The following is a description of a gene set: studied in species Homo sapiens Human Gene Set: GOCC_EUKARYOTIC_TRANSLATION_INITIATION_FACTOR_2B_COMPLEX A multisubunit guanine nucleotide exchange factor which catalyzes the exchange of GDP bound to initiation factor eIF2 for GTP, generating active eIF2-GTP. In humans, it is composed of five subunits, alpha, beta, delta, gamma and epsilon., and this is the list of marker genes: EIF2B4, EIF2B1, EIF2B3, EIF2B2 (eukaryotic translation initiation factor 2B subunit beta), EIF2B5